Given this list of marker genes MEGF8, LTBP4, EYA1 (EYA transcriptional coactivator and phosphatase 1), STX1A, ERF, ACAN, DDR2 (discoidin domain receptor tyrosine kinase 2), TAT (NCBI Gene Id 6898), WDR35, SON, IFT52, LRPPRC, EFEMP2, PEX1, BUB1B, MOCS2, PIK3R1, MYH3, CCDC22, KIF7, B9D1, CRELD1, NDUFB11, FBN1, COL9A1, PCGF2, IQSEC2, RSPO2, OSGEP, DCHS1, SETBP1, RAB23, DDB1, B3GLCT, IER3IP1, COL9A2, NBN, IREB2, NDP, ZNHIT3, COL5A1, PAX3, FIBP, LETM1, ADNP, APC, GLI2, SP7, ROR2, SIM1, NBAS, ATP7A, PIGG, GABRD, STAC3, NF1, ERI1, TFAP2B, KCNAB2, LINS1, HESX1, ACP5, DHX37, HDAC9, IFT81, CHD6, PIGN, UFD1, GJA8, NONO, NCF1, CDK5, RREB1, SKI, SH3PXD2B, SLC37A4, MLXIPL, SNRPN, CSPP1, ASXL3, OTUD5, NSD2, SYK, CLCF1, SC5D, ATRX, IRX5, PROP1, COL9A3, CA2, FLT4, ALX3 (NCBI Gene Id 93575), PIGV, MAN1B1, IFT140, PIGS, LAS1L, GPC6, ESCO2, BICD2, H4C9, RFC2, SLC35D1, EIF2AK3, CUL7, DICER1, GTF2IRD1, ANKH (ANKH inorganic pyrophosphate transport regulator), FN1, PLCB4, TGDS, GDF1, FGFR3, CDH11, DNAJC30, FGFR1, HBB, SATB2, BPTF, LBR, PDE4D, PDPN, SLC25A24, WASHC5, STRADA, POGZ, ALG12, FKBP6, FLNB, RNF13, POLR1A, CCDC88A, GRIN1 (NCBI Gene Id 2902), EBP, UBE4B (ubiquitination factor E4B), NEK9, H1-4, TECPR2, GNAI3, SPEN, KIF22, CDC42BPB, NEPRO, KAT6A, PURA, KDM6A, OBSL1, TMEM237, TMEM107, H3-3B, TRIO, ODC1, PSMC1, STX16 (syntaxin 16), DEPDC5, EP300, IPO8, CASZ1, IARS1, KCNQ1, FGFRL1, COL27A1, SLC29A3, COG4, P4HB, ESAM, MIR140, FGD1, WAC, PYCR2, HDAC8, CCBE1, SMAD2, TCTN1, CRKL, ASPH, TXNL4A, SF3B4, TGFB2, TBL2, AFF4, MAP2K1, TMEM231, GMNN (NCBI Gene Id 51053), MTHFS, TBX1, DLX4, WDR73, LRP1, BCR, CEP290, WNT3, PPP1R15B, LZTR1, YY1, CHST3, PTEN, TMEM165, MYSM1, PRDM16, CHD1, TMEM216, CDKN1C, ZNF407, PIGT, PEX7, IFT122, RRAS2, GSC, PEX12, COL2A1, CYP26C1, FOXG1, CEP120, ZNF462, PIGU, KCNQ1OT1, BCL11A, TBCE, COG1, PSMC3, EIF4H, EIF2S3, GTF2I, MED13L, LMX1B, KMT2B, MAF, SMC1A, ATP6V1A, LHX4, IDS (NCBI Gene Id 3423), GTF2IRD2, PRKAR1A, PTCH1, MAFB, RPS28, HK1, RPGRIP1, ZBTB20, MIPEP, HEPACAM, MAPK1, TUBB4A, GJA5, ACSL4, SLC9A7, WNT5A, RRAS, AGL, BGN, CTSK, YME1L1, EXTL3, B4GALT7, NAA10, H3-3A, MRAS, LTBP3, RHOA, HECW2, AUTS2, RTL1, SATB1, CC2D2A, PTH1R, NALCN (NCBI Gene Id 93074), NEK1 (NCBI Gene Id 51037), KMT2C, KRAS, RFWD3, TCTN2, DSE, SIX3 (NCBI Gene Id 6496), PUF60, GP1BB, TASP1, SEMA5A, MAD1L1, XYLT2, LUZP1, FLII, BRF1, MED12, RAP1B, PKD2, MSL3, LHX3, CAV1, NOTCH2, GPC3, TCF12, SHH, KIDINS220, SEC24C, COMT, MN1, PLOD3, ADAMTSL4, TMEM67, FAM50A, RDH11, COX15, NELFA, FLNA, LEMD2 (LEM domain nuclear envelope protein 2, NCBI Gene Id 221496), HOXB1, CRTAP, ATP6V0A2, RUNX2, IL11RA, GATA4, TCF20, MAP2K2, PCNT, PRMT7 (protein arginine methyltransferase 7), CCDC47, SPART, GATA6, JARID2, RYR1, SHANK3, RAB3GAP1, ITCH, ACTG1, SOX11, CAMK2B, ARID1B, MECP2, HNRNPH2, CHN1, MOCS1, PTRH2, CNOT1, ARVCF, EPB41L1, LARS1, TSR2, TRPM3, AEBP1, PPP1CB, TBX22, SF3B2, SH3BP2 (NCBI Gene Id 91018), FOXP1 (forkhead box P1), CSGALNACT1, TBL1XR1, SEMA3E, B3GAT3, ANKRD11, BCKDK, FOXC1, RNU4ATAC, SLC4A10, IDUA, SMAD4, MYT1L, WDR26, VPS13B, WBP11, SIX1, TONSL, HCCS, DLK1, TMCO1, RAB3GAP2, MGP, LMNA, ASXL1, H19, KIF15, HBA2, KIF11, PIGQ (NCBI Gene Id 9091), GNPAT, SVBP, HIRA, RASA2, SCARF2, MMP23B, LRRC32, GNB2, CNOT3, TUBGCP2, RERE, EHMT1, SOS1, SMCHD1, BCOR, PITX2, NKAP, GHR, OFD1, H4C5, DEAF1, H4C3, HNRNPH1, INTS1, GPC4, CTNND2 (catenin delta 2), FBXO11, B3GALT6, SERPINH1, TLK2, BMP2, STAG2, BRAF, HNRNPK, FGFR2, GRIA4, HSPA9, FZD2, MKS1, TCF4, EXT2, CDK10, TRMT10A, TSEN54, CREBBP, POLE, JAG1, POMGNT1, BMP4, NSMCE3, KLHL7, RAC3, EEF1A2, EDNRA, TMEM260, HBA1, POR, UFC1, LTBP1, FAM20C, CCDC8, PEPD, NRAS (NCBI Gene Id 4893), CILK1, CPLX1, EDN1, RAI1, SEC24D, CITED2, SLC35A2, CDC42 (NCBI Gene Id 998), NGF, NPR3, RAF1, NECTIN1, CLIP2, COX7B, WASF1, GRIA3, TCOF1, PLP1 (proteolipid protein 1), DTYMK, SETD1A, ANKRD17, MAP3K7, SALL1, NKX2-6, TFAP2A, SLC6A8, PAK2, ALX1, LIMK1, KDR, TGFB3, TMEM270, MTOR, MITF, SPTBN1, BICRA, AMPD2, CANT1, DVL1, PCLO, POP1, TWIST2, DLG3, BLM, STXBP1, ACTB, VPS33A, NPHP3, RPGRIP1L, DNMT3B, PIGA, SOST, WLS, B9D2, HS6ST2, IGF2, CTBP1, POLR1C, SH2B1, TWIST1, VPS35L, SNX14, INPPL1, SLC26A2, ZMIZ1, NSDHL, KCNJ2, DPYD, ZPR1, SALL4, HRAS, LRP2, FAT4, POU1F1, PRKCZ, MEG3, POLR1B, YARS1, MBD5, SEC23A, NOTCH3, SPECC1L, TBX4, NSMCE2 (NCBI Gene Id 286053), MESD, ZNF668, PAX1, NTRK1, ZFX, DPM1, DACT1, VPS37D, USB1, PYCR1, HSPG2, COL18A1, TFE3, HERC1, KDM6B, RIT1, NGLY1, DDX3X, PQBP1, GNAS, NKX2-5, RFX7, EFTUD2, XRCC4, BANF1, TXNDC15, POLR1D, SIX5, SNRPB, CTDP1, KCNH1, CLCN3, DVL3, CDK19, SETD1B, BAZ1B, LRP5, SOX9, NXN, WDR19, COL11A1, SMARCA2, CLCN4, DHODH, MAPK8IP3, POLR3A, ANK1, BBS7, GNPTAB, DPH5, FBLN5, JMJD1C, TP63, MID1, RNU4-2, TGFBR1, PDZD8, MAN2B1, HEATR3, ANTXR1, CHD7, HNRNPU, TAFAZZIN (NCBI Gene Id 6901), SOS2, ZFPM2, RPS26, SPRED2, CTCF, ZIC1, GPR101, PDGFRB, RLIM, UBE3B, COL1A1, IARS2 (NCBI Gene Id 55699), PRKACA, LRP4, SMAD3, AIP, GATA5, AMMECR1, GDF11, ATP6V1E1, CBL, PIK3CA, KAT6B, METTL27, HDAC4, UBE2A, AIFM1, CHD3, GORAB, ELN, PSPH, RBM8A, PTPN11, PIGB, FGF3, PRR12, TGFBR2, KCNE5, ELMO2, NFIX, CPE, PPP2R5D, LIFR, BUD23, RSPRY1, SLC2A10, DPYSL5, LARP7, KMT2E, CRLF1, KMT2D, MRPS14, COL11A2, SETD2, TCTN3, RNU12, OCRL, PSMD12, here is a description of the gene set: Human Gene Set: HP_ABNORMAL_MIDFACE_MORPHOLOGY studied in species Homo sapiens An anomaly of the midface, which is a region and not an anatomical term. It extends, superiorly, from the inferior orbital margin to, inferiorly, the level of nasal base. It is formed by the maxilla (upper jaw) and zygoma and cheeks and malar region. Traditionally, the nose and premaxilla are not included in the midface. Abnormal midface morphology